Given this list of marker genes RIPK3, 7a, 3a, BCL2L1, RIPK1, E, here is a description of the gene set: Reactome Pathway: SARS-CoV-1-mediated effects on programmed cell death Programmed cell death (PCD) pathways, including pyroptosis, apoptosis, and necroptosis, are induced in infected host cells as an integral part of host defense to restrict microbial infections and regulate inflammatory responses. Apoptosis is a noninflammatory form of cell death driven by the initiator caspase‑mediated cleavage of executioner caspase‑3 and ‑7. It facilitates degradation of the cellular contents but these are not released to the extracellular space. Necroptosis and pyroptosis are highly inflammatory forms of cell death that lead to cell lysis and release of pro‑inflammatory cytokines such as interleukin (IL)‑1β, tumour necrosis factor alpha (TNF‑α), IL6, IL18 and cellular contents, which can cause severe inflammation. Gasdermins (GSDMs) exert pore‑forming activity in inflammasome‑dependent pyroptosis, while the mixed lineage kinase domain‑like (MLKL) protein functions as the executioner during necroptosis (Shi J et AL. 2015; Upton JW et al. 2017). Inflammation is a fundamental protective mechanism in elimination of microorganisms, and is normally tightly regulated by certain mediators, in particular IL10, to promote resolution of inflammation. SARS‑CoV‑1 open reading frame‑3a (3a) binds host receptor interacting serine/threonine protein kinase 3 (RIPK3), facilitating RIPK3 oligomerization and the ion channel functionality of viral 3a, inducing inflammatory cell death and release of cellular contents (Yue Y et al. 2018). Enhanced production and release of proinflammatory cytokines leads to the cytokine storm that is considered to play a major role in SARS‑CoV type 1and 2 infections. The module also describes induction of apoptosis by SARS‑CoV‑1 E and 7a proteins through their interaction with anti‑apoptotic BCL2L1 (Yang Y et al. 2005; Tan YX et al. 2007). Low levels of BCL2L1 may lead to enhanced function of pro‑apoptotic molecules, contributing to the depletion of T lymphocytes by apoptosis (Yang Y et al. 2005). This may lead to the lymphopenia observed in SARS patients, particularly in severe cases (Diao B et al. 2020; Chen Z & Wherry EJ 2020). part of: SARS-CoV-1-host interactions studied in species Homo sapiens